Given this list of marker genes STAMBP, CARS2, NDE1, VPS13A, TCF4, TUBA1A, ATP1A3, GRIN1, POU4F1, OSTM1, SCN1A, SLC35A2, MTHFD1, VPS51, CAMTA1, CLCN3, EML1, here is a description of the gene set: studied in species Homo sapiens Human Gene Set: HP_HYPOPLASTIC_HIPPOCAMPUS Underdevelopment of the hippocampus. Hypoplastic hippocampus